Given this list of marker genes IL1RL2, VCL, CD79A, DHX9, UBE2B, H2BC15, PRSS3, RSAD2, KIF18A, IL37, CALML5, DCTN1, IGKV3-11, TRIM5, FTH1, IRAG2, PSMB8, PIK3CA, COPB1, LY96, NDC1, SARM1, KLC2, MAPK1, CLU, FAAP24, IGLV8-61, C4BPB, RNF114, VRK3, RAB9B, LCP2, PLPP5, HECTD1, MMP1, CFI, AP1S3, ITGAL, IFNL2, PPP3R1, LAMTOR2, CANX, DYNC1I1, SIGLEC8, CSTB, DEFB104A, NUP50, IGLV3-16, IL4R, RELA, MICA, PAFAH1B2, IL4, CLEC4G, NFATC2, H2AC18, DOK3, TRAIP, FYN, HERC5, RPS27A, FBXO7, CD200, C4B, GBP3, PTPRC, CBL, ARMC8, UBOX5, MS4A2, PGRMC1, TWIST1, IGHD, STAT2, RPS6KA3, MUC7, DEFB113, SLC27A2, CALM2 (NCBI Gene Id 805), UBA5, PRDX6, POLR3H, MAP2K4, B2M, ACTR2, PRG3, FANCM, DEGS1, HBB, APAF1, ARPC5, CD4 (NCBI Gene Id 920), IGLV7-46, KIR3DS1, POLR1C, TMEM63A, IGLV2-14, IL17F, F12, TUBB6, SIKE1, CANT1, POM121, PDAP1, DEFB108A, C9, CAMK2A, IGKV1-16, POLR3C, MIR142, DEFB129, APEH, B4GALT1, SIRPB1 (signal regulatory protein beta 1), CYBA, RNASEL, CLTC, IMPDH1, CD300LB, FBXW5, ARPC4, SEC61B, CCL22, SNCA, PSMD13, ATP6V1C2, TNFSF13, BATF, DNM1, fljB, HLA-DQA1, CNN2, FPR2, TNFRSF6B, ASB17, SPTBN2, LCN2 (NCBI Gene Id 3934), ARHGAP45, AOC1, VAMP3, LPCAT1, RCHY1, ARPC1A (NCBI Gene Id 10552), SH3GL2, ITPR3, KIF5C, ACTR1A, SIPA1, IGLV7-43, TRIM4, FANCL, MRC1, RILP, DYNC1LI1, MRE11 (NCBI Gene Id 4361), TNFSF8, PSMC6, IRF6, COMMD3, PIANP, BAIAP2, PELI3, KIF3A, DEFB115, GDI2 (NCBI Gene Id 2665), TAB3, CMTM6, DEFB1, MAVS, tat, RAPGEF1, FBXO32, UBA6, TCF7L1, VAMP7, ATP6V1G2, PLAC8, PTAFR (platelet activating factor receptor), SIRPA, FBXO22, CRISPLD2, CTSF, IL2RG, ENAH (ENAH actin regulator), PSMD8, COL2A1, DEFB110, NUP107, MAPK9, LY86, TRIM71, FBXO2, CSF1R (NCBI Gene Id 8156), A2M (NCBI Gene Id 2), EZH2, IGLV1-51, FBXW9, LAMTOR1, MIR152, IRS2, MMTAG2, IRF8, NUP155, SVIP, ATP6V0A4, IL36B, TRIM31, UBE2Q1, TNFSF11, CFD, SOX2, UBA3, SUMO1, CFHR2, SMURF2, FBXL14, POU2F1, HCST, ADGRE3, KIF22, IGKC, BRWD1, MLEC, CD226, TLR5, EIF4A2, H2BC5, TCN1, CSNK2A1, ANAPC5, POLR3A, H2AC7, MAP2K7, ARIH1, GCA, KLHL11, ACLY, VASP (vasodilator stimulated phosphoprotein), SFTPD, FCGR1A, MUC3B, KMT2C, KIR2DS1, rep, DZIP3, MEX3C, NPC2, FADD, NUP160, PSMA6, CD79B, AP2M1, ACTR10, SPTAN1, LGALS9, IFNA6, NCF4, IRF7, CCL19, IL6ST, DEFB135, MYO9B, DEFB133, SPHK1, TNFRSF13C, TNFRSF13B, CCL5, PSMB3, SH2D1B, BRK1, ISG15, FCGR2B, DERL2, S100A7, MID1, RBCK1, IFNB1, DYNLL1, NCR2, PLAU, PGM1, TARM1 (T cell-interacting, activating receptor on myeloid cells 1), CAPN1, RAB5C, MGST1, BTNL8, DUSP3, FRMPD3 (NCBI Gene Id 84443), ADAR, BECN1, TUBB1, KEAP1, AAAS, RAB37, CDC27 (NCBI Gene Id 996), FBXL4, TGFB1, CCR6 (C-C motif chemokine receptor 6), STBD1, SELL, BLNK, NFATC3, FKBP1A, BPIFA2, TREM2 (triggering receptor expressed on myeloid cells 2), SFTPA1, DCTN4, HLA-C (NCBI Gene Id 5674), OSBPL1A, TIFA, NUP85, SIGLEC9, TXK, FCN3, UBE2J2, MAP3K3, CD8A, BST1, KIF3B, TRAV19, TP53, AP1S2, DNASE1L1, ILF2, DEFB105A, IL1RL1, RNF135, NOS1, M, CTSZ, NUP42, STOM (stomatin), ATOX1, KLHL22 (NCBI Gene Id 84861), CDKN1B, BRI3, HLA-DRB3, INPP5D, COMMD9, IFITM1, PSMB7, PRKAG3, MIR424, POLR3D, ITGAM, BCL6, CLEC4D, ELMO2, EIF4G3, CEACAM1, TRIB3, NUP93, DCTN5, CD70, DERA, DUSP7, PSMA3 (NCBI Gene Id 5684), S100A1, PSMD12, PTPN22, ITGAV, CAMP, MRC2, MBL2, IGHV3-53, C1S, IL22RA2, AP1M2 (NCBI Gene Id 10053), DSP, PDCD4 (NCBI Gene Id 27250), SOCS1, EIF4E, PPP2R5D, VHL, NUP54, PTPRJ, WWP1, PLPP4, TRIM22, KPNA4, IGHV3-48, FZR1, FBXL13, TMEM179B, IFNA21, PSME1, CALM1, H2AC6, LILRB3, PRKACB, CSF2RA, BIN2, CUL7, MTOR, ABL2, TIMP1, MPO, CEACAM6, TRIM32, ACTG1 (NCBI Gene Id 71), CLCF1, LAMP2, HERC1, CRLF2, SERPINB6, RNASET2, PJA2, CD101, UBE2N, IFNA16, RNASE6, GOLGA7, SIGLEC6 (NCBI Gene Id 946), PNP, CARD11, IFNG, OTUD5, HNRNPDL, GSTA2, SHC1, IGHV3-13, RNASE8, STK11IP, ICOS, VPS35L, MUC5AC, MT2A, IRF2, CRP, CD81, Human respiratory syncytial virus A2, complete genome, FBXW12, EDA2R, IGLV2-33, TNFRSF1B, GLB1, BTN3A1, SIGLEC10, PIK3R5, NUP62, IGHM, CTSE, RIPK2, DEFB103A, FOSB, AGER, MYO1C, GBP5, LIFR, IL13, ATP6AP2, RAB5B, NRAS, AGO4, PTPN18, HSP90AA1, PSME2, IGLC2, PAK3 (p21 (RAC1) activated kinase 3), ITLN1, STUB1, TRIM2, ATP7A, KPNA7, RPN2, TRIM56, PLD4, IGLC6, TRIM62, RLIM, UBE2C, IL36A, IL17RB, KLHL13, CDC26, CXCL2, IL10RA, CCL4, BTNL2, IL18RAP, 3a, NBEAL2, GNLY, BCL10, OST4, CD36, CYLD, STAT1, IL1RN, TRIM37, FPR1, ATP6V0D1, ATP6V0A1, KPNA1, SIGLEC11, NCK1, IGHG1, GLYCAM1, TXN (thioredoxin), PDIA3, SERPINA1, CPN2, ASB3, ZAP70, LAT2, TAB2, CAPZA1, IL25, RHOF, TUBB3, CTSV, ARL8A, BTBD1, CCR1, TRIM10, KCTD7, RAC1 (Rac family small GTPase 1), HERC6, IGHV1-69, TNFRSF12A, EDA, CD22, IL5RA, PRLR, KLRG1, IFNA5, CBLL2, env, MASP1, RASGRP4, LRG1, IL6R, FBXL7, FBXO30 (F-box protein 30), KBTBD8, IL31RA, FLNB, SH2B3, SEC13, S100A11, CD14, SOCS6, MCEMP1, PTX3, MUC4, MUC17, NCR3LG1, ERAP2, CDC34, IGHV2-5, SDCBP, LBP, C6orf120, PLA2G2A (NCBI Gene Id 5320), RPN1, CAMK2B, gag, FURIN, C1R, HLA-DRA, CD160, MAPK14, TCF7L2, MIR340, FGA, KLRC1, IFNL3, HVCN1, CCND1, ASB5, COL3A1, POLR2H, NCKIPSD, DNAJC5, XAF1, H2AJ, TXLNA, ATP6V1B1, RNF216, ATG7, WWTR1, CAB39, LRSAM1, NUP153, KIR3DL2, TRIM8, IRF4, RNF126, SIAH1, TNF, NEDD4L, SIGLEC16, ARSB (NCBI Gene Id 411), MOSPD2, TRS1, MX2, ORM1, RORA, MAPK10, ATF6, MMP3, NFKBIE, PPP2CA, CD1A, HSPA1A, RNF19A, UBE2H, RBBP7, IRAK4, KLKB1, KLC1, CD300A, RPS6KA5, BTN2A2, CD209, B3GNT3, RAB31, DBNL, TUBAL3, POMC, SIGLEC5, OSTF1, STT3B, KLRD1, DOCK1, PILRA, CD300LG, ITGB1, ATP6V1H, PSMD6, WIPF1 (WAS/WASL interacting protein family member 1), CRTAM, HRG, CASP1, CASP8, EIF4E3, CD33, CBLB, FBXL20, BRD4, RNF125, MGAM, H2BC4, YES1, MUC21, SLAMF6, PTPN6, LIMK1, KIR2DL3, NLRP3, NUP37, CIITA, GBP1, NS, AKT1, DIAPH1 (NCBI Gene Id 1729, diaphanous related formin 1), FBXO44, IL1RAP, SEH1L, PSMB4, KNG1, TRIM68, IL17A, IL32, CR1, CSF3R, ISG20, CLEC12A, GRAP2, APP, POLR3K, CRKL, UBE4A, TRIM45, H2AZ2, C8A, FANCG, FCAR, SERPINB3, ADAM10, FOXO3, IL2RA, ACP3 (acid phosphatase 3), MYCN, TAP2, SIGLEC1, BIRC5, PRKAA2, IFNA2, IFI44, RAP1A, TLR1 (toll like receptor 1), RNASE2, MUCL1, UBR4, IL5, ABI2, HACE1, ICOSLG, MIR34C, AGO3, SUGT1, FCGR1BP, DUS2, GRB10, ORM2, AGA, CLEC5A, IGLV3-27, FGL2, CTNNB1, ERP44, PI3, STAT5B, IGLC7, MEFV, ALAD, KIR2DS2, CUL2 (NCBI Gene Id 8453), TEAD1, MAPK13, TASL, IL20, IGHV3-7, AGO2 (NCBI Gene Id 286109), IFI35, S, CPB2, ATP6V1G1, VTN (vitronectin), UBE2O, PLAUR, GATA3, S100P, ALDH3B1, TNFSF13B, LTB, IGLV10-54, KPNA2, CLEC6A, NPEPPS, CNPY3, HLA-DRB5, UBE2V1, UL83, EIF4G2 (eukaryotic translation initiation factor 4 gamma 2), FKBP5, UBE2F, TLR4, UBE2U, LRRC7, RASGRP1, CD34, SPOP, HA, FCN1, TRAPPC1, ROCK1, COL1A2 (NCBI Gene Id 1278), FNTB, AKT3, SEL1L, IL13RA2, FGR, H2AC20, CASP2, PTPN11, BPIFA1, POLR2K, PRKCE, ANXA1, FCGR2A, PA2G4, MAOA, ITGB5, CAMK2D (calcium/calmodulin dependent protein kinase II delta), KIR2DL1, PDPK1, CTSS, IGLV3-22, FLNA (filamin A), TRPM2, CTSH, HECTD3, SOCS5, VP3, UBE2G2, SEC61G (NCBI Gene Id 23480), SEC24D, KLHL9, CAPZB, EBI3, SOCS2, IL23A, LAIR2, S100A8, NFAM1, GSDME, H2BC12L, TRIM25, PRKDC, CRCP, TEAD4, PPP3CA, HERC3, IGHV4-34, KIF4A, FBXO6, PGAM1, FBXW4, CDC42, CD180, MANBA, ANAPC11, PSMA4, HERC2, MASP2, ATP6V1E1, GHR, ADAM8, IGLV2-18, RIGI, FBXL15, PSMD1, PIK3CG, CSF2, CD68, CISH, PSAP, PTPRN2, CD300LD, TRIM21, IGLV, HTN3, CFHR5, FBXL12, JUP, MAPK11, VTRNA2-1, PRSS2, ALOX5, TRIM50, HP, CASP5, RNF41 (NCBI Gene Id 93069), PVR, ADGRE5, MAPKAP1, PPP2R5B, IL21, GNS, EIF4G1, F13A1, CD300LF, TICAM1, DCTN6, IGKV2D-30, 7a, SURF4, RAG1, NCAM1, RACGAP1, CD247, PSMD3 (proteasome 26S subunit, non-ATPase 3), TUSC3, PSMD7, DCTN2, SIAH2, HN, KBTBD13, UBE2S (ubiquitin conjugating enzyme E2 S), CXCL8, CD3G, CXCL10, PRKCSH, S100A9, KIR2DL4, IRAK1, EED, DEFB109B, GBP7, MAP3K8, DEFB117 (NCBI Gene Id 245931), SPSB2, MAP2K3, IL22RA1, IFNA7, IL3, ERAP1, LNX1 (NCBI Gene Id 93989), EPPIN, USP14, IFIT2, GSTO1, EDAR, SEC24B, CD59, HLA-DOA, CAT, TNFSF18, IGLV2-23, MAPK8, ARPC1B, DTX4, ATP6V1C1, ASB2, OAS3, YWHAG, MYLIP, TNRC6A, IGHG2, LCP1, IGLV1-36, NUP214, GPI, PRKG1 (protein kinase cGMP-dependent 1), GGH (NCBI Gene Id 8836), TUBA3D, PAK1, ACAA1, AP2A2, DNAJC3, ASB7, RASGRP3 (RAS guanyl releasing protein 3), H3-3A, CTSD, SNAP25, ENPP4, LAIR1, OPTN, RPS6KA2, KIF5B, TNFRSF11B, AP2B1, CSK, SMARCA4, IL1RAPL1, IFNA17, TEC, POLR2E, TALDO1, IGLV3-12, PSMC1, CD177, DUSP4, DSC1 (desmocollin 1), CHGA, ADA2, DPY30, UFL1, PRKACG, NLRC4, IGLV6-57, MIR200B, TYROBP, SNRPA1, GYG1, ABCA13, C7, CFHR3, FBXO9, IGKV2D-40, SNAP29, STING1, ITCH, TRIM38, ATG5, UBE2I, CDA, VAT1, IGKV1D-39, TCIRG1, ATP8A1, CD53, APRT, PELI2, WAS, NOS3, HSPA9, ATP6V1F, ANAPC2, TRIM6, KCNAB2, ELOB, SIGLEC14, TNFRSF4, CHI3L1, ITGAX, FSCN1 (NCBI Gene Id 6624), DEFB130B, PPP2R1B, C4A, IL17C, DEFB126, DUSP6, RNF138, N4BP1, BLK, STAT6, FGG, GPR84, IFI44L, ospC3, JAK3, NCKAP1L, RAP1GAP (RAP1 GTPase activating protein), PSMD2, IGKV3-15, DHX36, AMPD3, TRIM26, TPR, NUP210, PSTPIP1, cd21, RASGRP2, AREL1, STAT3, PIM1, MAP3K1, IGLV2-11, UBB, IGKV4-1, VEGFA, C3AR1, PFKL, FBXO21, CPNE1, PELI1, UBE2V2 (ubiquitin conjugating enzyme E2 V2), RNF19B, CD200R1, TIRAP, SERPING1, IRAK2, BTBD6, KLHL20, CDH1, IFI6, UBE2D4, NPDC1, ATP6V0E2, CD44, XRCC6, C2, CCL2, ATG14, H2BC1, NUP133, PTPN23, MYH2, KIF2C, HLA-H, C6, PITPNA, CD1C, CFHR1, POLR3GL, COLEC12, PTPN20, LONRF1, NCR3, TUBA4A, RAP2B, SYK, KIF20A, IFIH1, FBXL21P, RNF123, LTN1, FBXL22, IGHG3, ABI1, PIK3R1, TLR6, H2AB1, TUBB4A (NCBI Gene Id 1864), TICAM2, UBE2Q2 (ubiquitin conjugating enzyme E2 Q2), YBX1, ANXA2, DEFB108B, C5, PPIA, EIF2S1, ACTR1B, CSF3, PSEN1, MUC5B, ASB12, CD207, RAB3D, PILRB, C1QBP, DEFB114, RAB7A, IFNL1, TUBA3E, PTPRB, BTN3A2, AGPAT2, NEK2, FUCA2, IL7, IL12B, H2BC21 (H2B clustered histone 21), NANOG, IFNA14, IFI30, RIPK1 (receptor interacting serine/threonine kinase 1), CXCR1, PYGB, ITGB2, TRIM14, USP18, KBTBD6, LILRA3, TLR2, STX1A, ARF1, TLR9, DHX58, HMGB1, hly, ELANE, LILRA5, SEM1, DDX41, OPRD1, IL17RE, DYNC1H1, PRKCQ, COLEC11, PSMA1, UBE2J1, IL36RN, CYFIP1, NKIRAS2, PRKAB2, IFNGR1, MIR93, IL1R1, NFKB1, IL9, H4C1, PRKRA, IST1, 8, PPBP, IKBIP, SIGIRR, YWHAZ, H2BC12, POLR3E (NCBI Gene Id 55718), OSCAR, MALT1, BPIFB2, HCK, TCF7 (transcription factor 7), KLHL2, IGKV3-20, IGLV1-47, TNIP2, RNF25, IL15RA, PGLYRP2, ALDOC, PAG1 (NCBI Gene Id 55824), IL12RB2, RBBP4, MUC1, SLC2A5 (solute carrier family 2 member 5), KIF23 (NCBI Gene Id 981), SOD1, MSN, IFNGR2, FANCA, ASB11, SIGLEC15, MUC6, HRNR, UBE2A, VAV2, VAPA, IL19, IL24, LEAP2, IFNAR2, IGHV3-23, TNFRSF9, MCL1, PDCD1, E, IGHE, RBBP5, REL, NEU1, CLEC2B, PTPN2, CRACR2A, IGKV2-28, EDARADD, FOLR3, TNRC6B (NCBI Gene Id 23112), DEFB107A, POLR3B, IFNAR1, NFKB2, LEF1, H3C1, RANBP2, UBE2G1, GAB2, NF2, FANCC, IFNLR1, PLD3, IL18BP, H2BC26, RBX1, RAP1B, MX1, DSN1, DEFB4A, SH2B1, CHRNB4, ITK, ADGRG3, HSPA1L, TYK2, CD74, TRIM17, TNFAIP6, KIR2DS4, CALR, KIR2DL2, CCL20, TNFRSF17, PIAS1, DEFB106A, REG3G, AHCYL1, AP1S1, KPNA3, BPIFB6, BCL2L1, MAPKAPK2, BTRC, CAND1, SP100, UNC93B1, FOS, MAPKAPK3, PADI2, CNTFR, MOV10, KIF3C, CSF1, CGAS, PDZD11, MADCAM1, ERLIN1, GRB2, GSN, PTK2, CTSL, SERPINB12, KIF2A, RNF14, UBE2D2, PTGES2, PGLYRP3, PSMB10, CASP10, UBA7, CKAP4, RAB24, PTK2B, PIK3AP1, SLCO4C1, TNFRSF14, CPPED1, HEBP2, SEC22B, COLEC10 (collectin subfamily member 10), GRN, KPNB1, TRIM11, PPP2R5C, SLC15A4, IGLV2-8, UBE2D1, LILRB5, TUBB8, RNF217 (NCBI Gene Id 154214), CD300C, IGHV3-11, porB, COL1A1, CSH1, CYSTM1, TARBP2, PSMC2, IL31, DEFB125 (defensin beta 125), UBE3C, CREG1, RHOU, SKP2, RAPGEF4 (NCBI Gene Id 11069), IL27RA, NCSTN, LAMTOR3 (late endosomal/lysosomal adaptor, MAPK and MTOR activator 3), EIF4A3, NCF2, IFITM2, RNASE7, IL2RB, IGLV4-60, PPP2R5A, NLRX1, LRRFIP1, TRIM46, DGAT1, TRIM69, AP1M1, TTR, POLR3G, OAS2, IGLV4-3, DCD, MYO10, ATP6V0D2, PTGS2, SH3RF1, SERPINB2, HLA-E, EIF2S3, SOD2, IRF5, TUBA3C, UBA1, IFNA1, SEMG1, RNF4, CCT2 (NCBI Gene Id 10576), CD93, PPP2R1A, RAB27A, ICAM5, HIF1A, FBXL16, ELOC, BTN3A3 (butyrophilin subfamily 3 member A3), TRAT1, PSMB9, HRAS, RNF111, KLRC2, IL15 (interleukin 15), DYNC1I2, RALA, EPX, KIF11, CAPZA2, MUC19, P4HB, PSMA5, SAA1, ZEB1, ANAPC1, HECW2, AAMP (NCBI Gene Id 14), DSG1, FABP5, IL23R, MAPK3, IL9R, IL34, IFIT1, PJA1, IGHV7-81, TRBC1, SQSTM1, TUBA1B, PPM1B, RETN, SARS coronavirus, complete genome, MEF2A, CCL11 (NCBI Gene Id 6356), EGR1, BLMH, CD58, HLA-DMB, DEFB134, PSMB2, FN1 (fibronectin 1), NAPRT, EIF4E2, REG3A, XRCC5, ITGA4, AP1G1, IQGAP1, CD27, TRIM36, IQGAP2, HLA-G, CREB1 (NCBI Gene Id 1385), IL18, CALM3, MEF2C, LPO, GBP2, CCL3L1, ASAH1, ALOX15, SDC1, BIRC3, BTK, ANAPC7, LMNB1, LRRC14, IL1R2, RNF220, TOMM70, CD86, SKP1, CDC23, SIGLEC7, DCAF1, TNFSF14, IL27, TUBB2A, RNF115, CLEC7A, ORAI1, TUBA8, PLEKHO2, TREML2, ART1, IMPDH2, CDK13, WASL, MUC16, H3C15, TOM1, GAA, DTX3L, CD1D, NOS2, DOCK2, JAK2, ATP6V0B, ANAPC10, SUZ12, DEFA5, BST2, ATF1, QPCT, MUC13, ICAM2, EEF2, TAPBP, DEFA3, ZNRF1, RPLP0, CAPZA3, FBXW11, FAAP20, RNF34, HECTD2, JAML, MIR34A, HMOX2, TRAF6, SEC24C, PTPN1 (protein tyrosine phosphatase non-receptor type 1), AIM2, MICB, IDH1 (isocitrate dehydrogenase (NADP(+)) 1), UBE2Z, ATG12, CCT8 (chaperonin containing TCP1 subunit 8), CHUK, IGKV1-5, CD40LG, IL17RC, SSA2, TANK, HSP70, KIF15, LTA4H, TRAF7, FBXW7 (NCBI Gene Id 55294), TPP2, IL10RB, PKP1, PROS1, CSNK2B, KIFAP3, FBXW2, CTSK, ULBP3, IGHV2-70, SLC44A2, PRL, LGMN, IL12A, UBR1, NUP43, DCTN3, IL1F10, PLD1, RHOG, IGKV2-30, TNFAIP3, IGLV11-55, WIPF3, KLHL3, PGGT1B, TBC1D10C, VCAM1, FBXO40, CAP1, IGHV4-59, UBE2E1, PSMC5, SOS2, KIR3DL1, WASF1, ICAM4, COL17A1, TKFC, TUBA1C, CPNE3, COTL1, IFNA13, TCP1, TMEM258, PTPN9, PTPN5, FBXO31, PSMA2 (proteasome 20S subunit alpha 2), RAB14, IGKV1D-16, HGSNAT, RAB3A, TRIM48, H2AC4, IL22, UBE2K, MMP8, POLR3F, STXBP2, ZBP1, GLIPR1, LCK, CEACAM3, DEFB116, DEFB123, CD99, CXADR, SLC2A3, CLEC10A, CLEC4E, HLA-DMA (major histocompatibility complex, class II, DM alpha), EP300, MYD88, JAK1, IGKV2-29 (NCBI Gene Id 28920), ASH2L, PTPN14, KLHL21, TNFRSF18, LTBR, TNFSF12, PIK3CD, ACTR3, HLA-DPA1, DNM3, TRIM3, STIM1, KRT1, RAB4B, ITGB7, MAP3K7, RELB, HNRNPA2B1, UBR2, RICTOR, LGALS3, PTPN13, SEC61A2, RAP1GAP2, ZNRF2, CLTA, H2AX, NLRC3, IGHV3-30, fliC, HERC4, RNF144B, CD19, NUP98, SNAP23, MIR200C, RAPGEF3, BTN1A1, IGF2R, IKBKG, CFP, TXNDC5, CST3, FGB, FCGR1B, LAMA5, NPM1, ASB4, GALNS, FBXO4, THEM4, PRCP, PIK3R3, PPL, BPIFB4, IL1B, SRC, LYZ, PPP2R5E, TOLLIP, IL11, CHIT1, ACTB, C3, H2BC13, S100A12, BPI (NCBI Gene Id 671), TNFSF6, PRG2, MUC15, IGKV3D-20, CXCR2, KLRK1, ERLIN2, ASB15, SH3KBP1, RAC2, LILRA2, TNFRSF25, GSTP1, UNC13D, EIF4A1 (NCBI Gene Id 1973), H2BC9, IGKV1-39, CTLA4, MNDA, LRRC41, IRAK3, CUL5 (NCBI Gene Id 8065), CRK, FBXO27, MUC3A, CD63, VCP (valosin containing protein), UBE2L6, PSMD14, PTPN4, KLC3, PPP3CB, IL12RB1, RNF7, JUN, KMT2A, RBSN, HPSE, NLRP4, CEP290, SERPINB10, NFASC, KIR2DS5, IP6K2, CTF1, ASB8, FYB1, TRIM34, POLR2F, TRIM9, ICAM1, ATP6V1D, CCNF, MYO5A, C5AR2, PSMB1, IGLV3-21, KIF2B, RNF182, TRAC, IGLV5-37, VAV1, PIK3R2, PRR5, FBXL19, ASB9, TUBB2B, CLEC2D, IGLC3, SEC24A, NHLRC3, S100B, ATP6V0E1 (ATPase H+ transporting V0 subunit e1), HLA-A (major histocompatibility complex, class I, A), FBXL18, BTN2A1, C1QB, CD1B, SOS1, PPIE, SAMHD1 (SAM and HD domain containing deoxynucleoside triphosphate triphosphohydrolase 1), C5AR1, SERPINA3, TAP1, FAF2, TUBB, LNPEP, RHOA, DEFB121, NOD2, SRP14, LYN, RNF185, S1PR1, ANPEP, IGLV3-1, IGKV1-12, H2BC14, LILRA1, CDK1, TSLP, PGM2, IFNA4, IGHV, CFH, CTSG, DEFB132, GHDC, mip, IGHV3-9, PPP2CB, IFIT5, CCR5, FBXL3, SFN, KIF26A, MTAP, DYNLT1, CUL3, FCER2, DEFB124, NLRP1, H2BC17, IL2, IGLV4-69, ASB13, TEAD2, THOC5, CA1, ICAM3, FLT3, DEFA6, ZBTB16, HLA-F, GLA, MGRN1, RAP2C, AZU1, LAG3, CENPS, BTNL9 (butyrophilin like 9), APOB, CDKN1A, SCAMP1, UBA52, IL20RA, PGLYRP4, H2BC3, ITPR2, IRS1, TUBB4B, PRKACA, CNTF, RAB10, TREML1, F2, ASB10, OAS1, HK3, CTSA, UBE2R2, ANAPC13, SEC23A, PTEN, RNF130, PGLYRP1, TRAF3, ALDOA, KIF4B, POLR2L, LILRA4, FAAP100, ARIH2, CTSC, PYCARD, LTF, TNFSF9, MIR148A, HSP90B1, BIRC2, IL11RA, NUP205, MIB2, TRIM29, TNFRSF11A, IFI16, C1QC, IGLC1, MIF, RAB44, PRKAG2, FBXO11, MYC, SLA, PRKCD, TMC6, FRK, FLT3LG, PIK3C3, JUNB, TRIP12, HLA-DPB1, CASP3, IGHV1-2, KCMF1, HMOX1, DAD1, GM2A, WDR5, TRIM39, PSMB5, HLA-DQB2, PTPRZ1, A1BG, FCER1A, UBE3B, TEAD3, SEC31A, YAP1, FBXL5, IL21R, ELMO1, ARSA, DEFB112, NUP58, CCL17 (NCBI Gene Id 6361), DEFB127, CARD9, RNASE3, HLA-DOB, MAPK12, EPAS1, MMP25 (matrix metallopeptidase 25), PSMC4, CFB, CR2, MIRLET7A1 (microRNA let-7a-1), PRKAA1, FBXO15, CSF2RB, TUBA1A, POLR1D, IL33, TIMP2, CD3D, GH1 (NCBI Gene Id 2688), FBXO17, FCN2, ERLEC1, YWHAB, ANO6, FBXL8, NFKBIB, AP2S1, RAG2, S100A7A, SFTPA2, FLG2, ANAPC4, LAT (linker for activation of T cells), QSOX1, DEFB131A, NKIRAS1, EVL, FOXO1, CDK4, UBE2W, IGKV1D-33, UBE3A, CD46, H2AZ1, HLA-DRB1, NME2, GAN, ATAD3B, IL3RA, CD96, KLHL5, IGHG4, VAMP2, ABCE1 (NCBI Gene Id 6059), HLA-DRB4, CREBBP, SLAMF7, RAET1E, UBE2E2, ASB16, KRAS, TNFRSF1A, PRTN3, CSNK2A2, LIF, IL1A, ATF2, CRISP3, KIF5A, MUC2, IL36G, UBE2L3, NUP188, VIM, SEC61A1, PRKAB1, GSDMD, PSMD11, NUP88 (NCBI Gene Id 4927), OPRM1, TUBA4B, ASB18, SMAD3, PML, TNRC6C, TRAV8-4, HNRNPF, CFHR4, PANX1, BCL2, ATP6V1B2, EIF2S2, DEFA1, KLRB1, IL18R1, PDE12, SYNGR1, ATP6V1G3, IGHV1-46, UBC, FCGR3B, RNF6 (NCBI Gene Id 6049), TRAF2, STX3, WSB1, ASB6, OLR1, RNF5, TLR10, CTSO, ADRM1, NCF1, FUCA1, GBP6, CCL3, IFITM3, MYH9, NIT2, HLA-DQB1, MAPT, BPIFB1 (NCBI Gene Id 92747), WIPF2, PRKN, N, BTLA, HSPA5, LRR1, PIK3CB, SERPINB1, TNFSF15, VAV3, SOCS3, FBXW10, GZMM, DEFB130A, KLHL41, CDC16, CYFIP2, LILRB4 (leukocyte immunoglobulin like receptor B4), IL10, RAB6A, IL6, TAB1, RAE1, IL26, POM121C (POM121 transmembrane nucleoporin C), C8G, GAB3, STAT5A, HLA-B, ECSIT, AHSG, KLHL25, IGKV5-2, ATP8B4, TXNIP, HSP90AB1, HLA-DQA2, PLCG2, PCBP2, DAPP1, PSMC3, IL7R, P2RX1, MLST8, CASP9, NOD1, NDUFC2, IL13RA1, C4BPA, GBP4, SLC11A1, PIGR (polymeric immunoglobulin receptor), PSMA7, CENPE, IGLV1-44, TRPC1, TNFRSF8, IL17RA, DEFB136, ABL1, P2RX7, DPP7, OLFM4, BCAP31, IL20RB, CDC20 (NCBI Gene Id 991), H2BC11, MUC20, LILRB2, DNM2, AIP, PRDX4, MVP, LTA, ARPC2, SPSB1, DDOST, TLR3, NEDD4, IGKV1D-12, TMBIM1, EEA1, HAVCR2, TAX1BP1, INPPL1, UBE2M, MAN2B1, ASB14, IGLV5-45, IFNA10, VNN1 (vanin 1), ATF3, FGF2, IGLV3-19, CD80, TRIM35 (NCBI Gene Id 23087), JUND, KBTBD7, UBE3D (ubiquitin protein ligase E3D), PRKCB, AGL, TMT1A, CYB5R3, UBAC1, ARPC3, NCKAP1, CEBPD, CD8B, PIK3R6, EEF1A1, NFE2L2, C1QA, DDX3X, EIF2AK3, PYGL, OASL, MME, FBXO10, IKBKB, IFI27, ATP6V1E2 (ATPase H+ transporting V1 subunit E2), PLA2G6, DEFB118, NFKBIA, PRKAG1 (NCBI Gene Id 5571), STT3A, UBE2D3, CRLF1, AKT2, ILF3, PIK3R4, UBE2E3, ATP11A, IGLV1-40 (immunoglobulin lambda variable 1-40), RORC, TLR7, DET1, IKBKE, IL16, DYNC1LI2, NECTIN2, IRF9, NCR1, MAPK7, CD47, CXCL1, TRBV12-3, CD40, CFL1, C8B, CD274, GUSB, HSPA1B, SMAD7, 9b, IGKV2D-28, MAP3K14, TUBB8B, OSTC, TREX1, PDCD1LG2, GH2, WASF3, OSMR, RPS6KA1, FBXW8, CLEC4C, KPNA5, CENPX, PSMB6, AGO1, GMFG, ATP6V1A, TRIM63, PLD2, HUWE1, STAT4, IRF1, HSPA8, ASB1, ORAI2, KLHL42, TRIM41, RAF1, SPSB4, RBBP6, MKRN1, XDH, ATP11B, NLRC5, TREM1, PDXK, PAK2, FBXO41, SLA2, FNTA, OSM (NCBI Gene Id 5008), COPS5 (COP9 signalosome subunit 5), STX4, CEACAM8, TNFSF4, IGKV1-33, CAMK2G, DEFA4, BOLA2, DNAJC13, ATP6V0A2, ADAM17, ORMDL3, ATP6V0C (NCBI Gene Id 527), FANCB (NCBI Gene Id 2187), UNKL, TRAV29DV5, LILRA6, SH2D1A, IFIT3, CD28, DEFB119, HEXB, FTL, DERL1, IRF3, ELK1, FANCE, VAMP8, ITPR1, DERL3 (NCBI Gene Id 91319, derlin 3), ALPK1, TREML4, RNF213, THOP1, WASF2, MIR429, EIF2AK2, LMO7, prgJ, NDN, HTN1, TBK1, IGKV1-17, MIR34B, PTPN12, PIN1 (NCBI Gene Id 5300), CUL1, YPEL5, NFATC1, SAR1B, STK10, RIPK3, CCR2, MIR140, CD300E, IGHV4-39, IGHV3-33, MAP2K6, BCL2L11, RAB18, KLRF1, FCER1G, PKM, SIGLEC12, AP1B1, KCTD6, IGLV3-25, MMP9, TRBV7-9, OS9, KLC4, CD3E, CD55, TMEM30A, MS4A3, PTPN7, NUP35, CLEC4A, HSPA6, SLPI, CYBB, MUC12, DYNLL2, MAGT1, FCGR3A (Fc gamma receptor IIIa), HGF, PECAM1, GSK3B, CTSB, MAP2K1, TLR8, CASP4, IFNA8, FANCF, PLCG1, DEFB128, FASLG, GLMN, ULBP1, MIR138-1, HSPA2, AP2A1, SMURF1, CPN1, TSPAN14 (tetraspanin 14), LILRB1, ARHGAP9, MMP2 (matrix metallopeptidase 2), LAMP1, H2AC14, 1C, ARG1, here is a description of the gene set: Reactome Pathway: Immune System studied in species Homo sapiens Humans are exposed to millions of potential pathogens daily, through contact, ingestion, and inhalation. Our ability to avoid infection depends on the adaptive immune system and during the first critical hours and days of exposure to a new pathogen, our innate immune system.